The following is a description of a gene set: Human Gene Set: GOMF_ATPASE_COUPLED_MONOATOMIC_CATION_TRANSMEMBRANE_TRANSPORTER_ACTIVITY Enables the transfer of a solute or solutes from one side of a membrane to the other according to the reaction: ATP + H2O + cation(out) = ADP + phosphate + cation(in). species: Homo sapiens, and this is the list of marker genes: ATP2B3, ATP1A4 (NCBI Gene Id 480), ATP6V1B2, ATP4A, ATP7B, ATP13A5, ATP6V1E1, ATP6V0D2, KCNJ11, ATP6V1D, ATP2B4, ATP6V1G2, ATP6V0D1, ATP6V0E2, ATP2C1, ATP1A2, ATP1A3, ATP6V1A, ATP6V1E2, ATP13A4, ATP6V1G3, ATP13A2, ATP7A, ATP6V0A1, ABCC9, TCIRG1, ATP2A3, ATP6V0C, ATP2B1, ATP12A, ATP2B2, TMEM94, ATP6V1F, ATP5F1B, ATP6V1C2, ATP4B, ATP2A2, ATP6V1C1, ATP6V0A2 (ATPase H+ transporting V0 subunit a2), ATP6V0A4, ATP6V1H, ATP1B1, ATP6V0E1, ATP13A3, ATP13A1, ATP6V1B1, KCNJ8, ATP2C2, ABCC8, ATP1A1, ATP6V1G1 (ATPase H+ transporting V1 subunit G1), ATP2A1, ATP8A1, ATP6V0B